The following is a description of a gene set: Human Gene Set: GOBP_MEMBRANE_ORGANIZATION species: Homo sapiens A process which results in the assembly, arrangement of constituent parts, or disassembly of a membrane. A membrane is a double layer of lipid molecules that encloses all cells, and, in eukaryotes, many organelles; may be a single or double lipid bilayer; also includes associated proteins., and this is the list of marker genes: PACSIN2, RAB2A, SYT3, RTL10, GCA, MTX1, TMEM175, MAPK15, MUSK, STPG1, RTP1, ATP11C, RAB1A, LAPTM4B, ALKBH4, EMC8, LLCFC1, BLOC1S2, CAMK2A, TRAM2, CCDC47, HDAC3, VAPA, NRCAM, TRAPPC3, NSF (N-ethylmaleimide sensitive factor, vesicle fusing ATPase), ELMO1, MYOC, PITPNM2, RTP4, MICALL1, GNPAT (NCBI Gene Id 8443), HIP1R, APPL2, OPA1, SLC25A4, GDNF, DCST1, ANK2, FASLG, TOR1A, VPS8, THEM4, EMD, BTBD8, VAV3, EXOC7, RTP2, FNBP1L, COL5A1, STX2, TRIM72, EXOC6, AP1G1, TOMM7, MYH9, GLTPD2, DNM1, XKR6, LYZL4 (lysozyme like 4), GOSR2, TRAPPC13, FCHO2, DPP4, BCL2L11, PEF1, RAB8A, FNTA, ABCA2, CIBAR1, IL1RAPL1, CORO1A (coronin 1A), SPACA5, KCNIP2, PLEKHM1, REEP5, VDAC2, TRAPPC8, SPIRE2, STX16, CNTN2, ZFYVE19, SLC7A11, TRAPPC4, CLCN2, VPS4B, ANO9, MESD, VCPIP1, PMP2, ESYT1, SEC13, MAFB, CCDC88A, BLTP1, AP3M2, MITD1, TOM1, FZD9, ATG9B, PITPNC1, NAPA, CRISP1, ATP8B3, SYNGR1 (synaptogyrin 1), RHOT1, TRAPPC2B, PITPNA, CTSL, ATP2C1, PLSCR4, SNAP91, VTI1B, PDCD6IP, BOK, RAB7A, MTMR3, ARL6IP1, ABCA3, PMAIP1, SPAM1 (sperm adhesion molecule 1), VPS37B, SPACA3, PPP6C, BET1L, GOLPH3L, ARFGAP2, PIP4K2B (NCBI Gene Id 8396), MIR29A, RPH3A (NCBI Gene Id 22895), PRELID1, SLC2A4, BAD, BAX, DOCK1, BNIP3, VPS33B, SNX3, NOL3, EYA2, EGFR, TBC1D4, SYNJ2, VPS33A, RUBCNL, ZDHHC2, ZNRF2, SCP2 (sterol carrier protein 2), EMC1, MTMR4, PDCD6, SSH1, AP3S2, GPER1, BIN2, DEGS1 (NCBI Gene Id 8560), ATP8A1, BNIP3L, WDR54, ROMO1, KIAA0319L, CLN3, NLGN2, VPS41, DLG4, SURF4, ETNPPL, CLCN3 (NCBI Gene Id 133073), ITGAM, PTPRD, UBL4A, NUP155, SLC25A6, NLGN4X, UGCG, COLEC12, NAPG, SCAP, ATP8B2, MTCH2, CHRDL1, TSNARE1, RFT1, OMA1, ALKBH7, ATP8B1, S100A10, ANKFY1, IST1, NOX5, GULP1, ARFGAP3 (ADP ribosylation factor GTPase activating protein 3), CHMP7, TMEM41B, GRIN3B, SEC31A, SEC23A, ANXA1, AP3B1, TRAM1, PLK1, PREB, MYRF, CRK, FRRS1L, C2CD2L, ANO3, CPLX2, SH3GLB1, SLC25A46, VPS37D, MMGT1, BLOC1S6, FCER1G, MYOF, ATL1, SIRT2, CHMP1A, XRCC4, HK2, ZNRF1, TOR1AIP2, HUWE1, SGTA, SPPL2C, APOO, DES, SLC25A5, RFTN1 (raftlin, lipid raft linker 1), EMC10, PACSIN1, DCST2, VAPB, TRIAP1, BLTP3B, TRARG1, ABCB1, HAVCR1, CHMP6, SLC35F6, SNAP29, VRK1, TMEM102, NEK6, VIPAS39, CLTRN, SERPINA5, SYPL2, UMOD, LAPTM5, MPV17L, C16orf92, MX2, CHCHD3 (NCBI Gene Id 54927), TMEM147, MX1, SELENON, ATP5IF1, DOCK2, ZMYND8, CALM3, ITGA2, CHMP2B, OXA1L, REEP1, XKR9, TMEM95, ARHGAP12, ARHGAP25, NOMO1, VMP1, VPS4A, COLQ, RAPSN, VAMP7, LEMD2, RELN, IRAG2, SPACA5B, ROPN1B, SERINC5 (NCBI Gene Id 256987), ATP9B, USO1, MVB12A (NCBI Gene Id 93343), CPTP, TRAPPC2, STX7, SEC22B, ZMPSTE24, SEC24A, SYT5, TMEFF2, TMEM30B, BECN1, SNX9, DMPK, SOD1, MTSS1, ARV1, DIAPH3, PITPNM1, TRAM1L1 (NCBI Gene Id 133022), CIDEB, LRP4, CPLX1, CSRP3, NOMO3, CHMP4A, VPS37A, SEPTIN8, DLG1, PTEN, AGRN, XKR4, TOMM20, TRAPPC5, TRPC5, EMC3, PIK3C2A, EMC9, STX1B, RILP, CNTNAP2, NDRG1, PLA2G5, TRMT10B, STAT3, SHANK3, MTX3, GLIPR1L1, VAMP1, NCKAP1L, BAIAP2L1, GET4, UBAP1, GOSR1, UQCC3, TRAPPC2L, TOR1AIP1, NUP93, REEP2, TSG101, SCLT1, CAMLG, BNIP1, SYT13, STX10, STX11, RCC1, NPC1, EXOC1, CAVIN2, ANO4, ANKRD27, AZIN2, AGK, RABEP1, ATG2B, CHMP3, WNK1, MYADM, TIMM8B, TLCD2, ABCG1, BAIAP2L2, ATP11A, CAV2 (NCBI Gene Id 858), TGFBRAP1, SYT8, ILK, BCL2, VAMP3, FREY1, PLSCR5, VPS28, GLTP, VPS37C, TRAPPC10, CERT1, TIMM50, SEC23B, ADAM2, EXOC5, FA2H, CAV3, DBNL, BROX, PLSCR2, TLCD1, CRIPT, SOX30, RUFY1, CHCHD10, DVL1, EMC4, VPS25, PRKCB, TMEM201, AKAP8L, ARHGAP11B, HGS, RAB3A, KCNN4, PPM1K (NCBI Gene Id 152926), NRXN1, SEC24D, PALS1, MFSD2A, MFN2, GET1, APOE, P2RX7, CIDEA, LRCH4, OTOF, SLAMF1, CD36, LARGE1, STXBP6, PIP4K2A, CHP1, PLSCR3, ATG2A, VPS36, ATP1B1, SEC16A, BCS1L, MEGF10, CD2, GATA2, STX8, PINK1, STX5, DOK7, CD300A, TMEM43, SEC24C, PRELID3A, SYT2, LMNA, TIMM8A, TMCO1, BAG6, DNAJA3, RAB31, LRRC4, SPG11, PLEKHA8, SAR1A (NCBI Gene Id 56909), ALOX15, LYZL6, RABIF, TMEM11, TMEM63B, GBF1, TIE1, LMNB1, PITPNB, CRB1, TRAPPC6A, DNM1L, DCTN1, WHAMM (NCBI Gene Id 123720), MTCH1, UBXN2B, GSK3B, USE1, APOOL (apolipoprotein O like), GPHN, TRAPPC11, IER3, CHMP4BP1, ATR, SEC31B, RAB20, SPIRE1, FOLR1, RILPL2, INSIG1, CUL3, PLTP, RAB7B, C3, ACE2, HSPA9, SERP1, EMC7, PRELID2, GSK3A, LAT, YJEFN3 (YjeF N-terminal domain containing 3), OSBPL2, TIMM10B, XKR8, SPACA6, EXOC3, STAP1, RTP3, RHOA, RIMS1, TOMM22, PIKFYVE, CD2AP, VPS16, SNAP47, CD24, SH3BP1, RAB14, TOMM5, STX6, NECTIN2, RUFY4, SMPD1, PICK1, MICU1, SNAP23, STX4, CLPTM1L, CXCR4, ATP10A, SLC9A1, BIN3, GRXCR1, EEA1, MOAP1, TNFAIP8L3, NDUFA13, MARCO, STAM, MSR1, UVRAG, AAK1, STX1A, GOLPH3, TIMM10, ETV5, SPTBN4, SERINC2, HSPA1A, HACE1, IZUMO1, AFG3L2, PRRT2, SPTBN1, RILPL1, MIR138-1, RAB39A, HSPA8 (NCBI Gene Id 3312), STX18, ABCD2 (NCBI Gene Id 225), AR, XKR7, EPHB2, DHCR24, NLGN1, EMC2, ERC2, NRXN2, A4GALT, SYT7, STEEP1, PRKCA, TMEM170A, TFG, ATF2, BANF1, IZUMO1R, MIR17, SEC22A, RAB34, TREM2 (NCBI Gene Id 54209), ATG9A, SYNGR2, FOLR2, CD9, TOMM40, FARP1, PACSIN3, PIP5K1C, MIR26A1, SYT1, TP53, FLOT1, YIPF7, TRAPPC9, NCLN, TIMM22, RAC1, ABCB4, SYTL4, MYH10, GLDN, COX18, NAIF1, AP3D1, PLEKHA8P1, NAXE, CH25H, EXOC6B, TOR1B, TRDN, ABCA12, MIR29C, FCGR1A, PRKCI, COL6A1, CLN8, ABCA1, SNCA, TPST2, CAV1, RPH3AL, TRAPPC1, ATP2A2, PTPRC, F2RL1, TMCC1, EMP2, FCHSD1, ADCK1, VPS39, VTI1A, ATP13A2, ATP10D, WASL, SIVA1 (NCBI Gene Id 89639), CIDEC, NOX1, AKT1, DMKN, MAL, OCRL, ABCA4, GBA2, ATP10B, VPS11, MUL1, FCGR2B, AP3B2, JOSD1, TMEM33, SEC61A1, DOC2B, EPB41L3, PITPNM3, ANO5, EXOC2, VAMP4, EXOC4, BAK1, ABCC1, NHERF1, MYMK, TAFAZZIN, ARF1, TIMM29, LETM1, OSBPL8, PEX5, PARP11, GET3, CDK1, PPIF, EXOC8, SAMD9, FOLR3, CHMP2A, TIMD4, DCSTAMP, TMED2, OSBPL5 (NCBI Gene Id 57656), AP3S1, SNAP25, CDC42, STARD7, STXBP1, MIR29B1, ABCA7, TBC1D20, CLU, BCL2L1, NSFL1C, ATP9A, ARL8B, SNX33, DNM2, GHITM, MICOS13, TMED10, NEMP1, LPIN1, GSN, AURKB, TOMM70, TMEM30A, ANXA7, ARL6, PICALM, GRIK5, SH3TC2, UBXN2A, CR1 (complement C3b/C4b receptor 1 (Knops blood group)), EMC6, BID, SPTA1, AIF1, MVB12B, ANXA2, PLCG2, REEP3, THBS1, LMNB2, MYMX, TMED9, TRAPPC12, YKT6, CHCHD6, CHMP1B, KCNB1, CHMP4C, SAR1B, WDR83OS, PPT1, SERINC3, NOMO2, SYP, SHISA7, BIN1, SPAST, SLC66A2, PLSCR1, ATP8A2, MTSS2, YIPF5, SYNJ1, ATL3, TRAPPC6B, TIMM9, GCLC, YIPF4, ATP8B4, EHD2, DOC2A, CEP55, MYO18A, GLRB, PAFAH1B1, RTP5, SPATA46, CPLX3, VAMP8, DNM3, ASAP1, PLAAT3, CHMP4B (charged multivesicular body protein 4B), SMURF1, TMEM14A, BET1, CPLANE2, SGCZ, CTDNEP1, EQTN, ATP11B, SPHK1, SYT11, LPCAT3, RER1, REEP4, MICALL2, TARDBP, STX12, SPESP1, MAIP1 (matrix AAA peptidase interacting protein 1), MTTP, TTPA, DNAJC11, STX3, ACAA2, AP2M1, CPLX4, SNAPIN, SAMM50, SHISA6, SEC24B, CORO1C, VAMP2, STAM2, NKD2, C9orf72, SNF8, BAIAP2, ITGB2, ANO7, IMMT, CHRNB1, UBE2I, SPART, KLHL12, STX17, PLEC, MIA3, MBP, MTX2, RTN4, SYT9, PRX, SLC25A31, RHOT2, LPCAT2 (NCBI Gene Id 54947), TIMM13, MICOS10, KIF20A, ATL2, CDH2, SLC4A1, STX19, LRRK2, CRKL, TOMM6, CSNK1D, CHMP5, RAB5IF, SYT4, PRKN, LHFPL4, AHNAK, PRELID3B, C2CD5, TMEM126A, SH3GLB2 (NCBI Gene Id 56904), ADGRB1, ABCD1, NLGN3, IQGAP1, VPS18, ANK3, CASP7, ANKLE2, SPG7, FCHSD2, SLC30A1, AKT2, TGFB2, ZNF205, ANO6, RAB4B, GAS6, SNX18